Given this list of marker genes Avpr1b, Ang, Plaa, Ang6 (angiogenin, ribonuclease A family, member 6), Ang5, Agtr1b (angiotensin II receptor, type 1b), Ang2, Ang4, Agtr1a, here is a description of the gene set: Mouse Gene Set: GOBP_POSITIVE_REGULATION_OF_PHOSPHOLIPASE_A2_ACTIVITY Any process that activates or increases the activity of the enzyme phospholipase A2. species: Mus musculus